Given this list of marker genes Zfp275, Gbp9, Pcdhac1, Lurap1, Snca, Cep97, Pcdha5, Dzip1, Ppp3cb, Ndrg1 (N-myc downstream regulated gene 1), Thrb, Cdh8, Nfs1, Wasf1, U2surp, Sema5a, Srsf11, Unc5c, Mrps14, Kif1b, Il22ra2, Tmem255a, Nemp1, Pcdha7, Pcdha6, Sall3, Eln (elastin), Rtkn, Trim21, Pcdha10, Aldh3a2, Ufd1, Marchf11, Ddc, Ly6g, Ajap1 (NCBI Gene Id 433810), Trim33, Khnyn, Derl2, Dner, Brs3, Tcp11l2, Pcdhac2, Jrk, Kpna1 (karyopherin subunit alpha 1), Pcdha3, Rb1cc1, Minar1, Fgf13, Tagln2, Kcna2, Tcim, Pcdhb19, Nppc, Ppip5k1 (NCBI Gene Id 327655), Eif4e, Patj, Nsf, Zfp711, Pcdha12, Ap4m1, Glcci1, Actr2, Csrnp3, Arhgap18, Tmub2, Dlgap4, Ptpn9, Pcdha9, Pcdha4, Zdhhc9, Nr2c2, Rsbn1, Nsg2, Tmem65, Ralgapb, Kdm4b, Ywhaz, Tmem208, Ppfia2, Pcdha11, Mapk1, Pbxip1, Kbtbd8, Spart, Rab1a, Pcdha1, Smim29, Wdr7, Or7e176 (olfactory receptor family 7 subfamily E member 176), Tmcc1, Zfp704, Hipk3, Garem1, Pcdha2, P4ha2, Vangl1, Lrp8, Rwdd1, Aopep, Zfp759, here is a description of the gene set: Genes predicted to be targets of miRBase v22 microRNA mmu_miR_693_5p in miRDB v6.0 with MirTarget v4 prediction scores > 80 (high confidence targets). from publication Chen Y, Wang X (PMID 31504780) studied in species Mus musculus Mouse Gene Set: MIR_693_5P